Given this list of marker genes ASAH1, FAM83B, LINC02995, RNU6-924P, MALSU1, BRWD1, PRMT5-AS1, HSPA4, ZNF48, LINC00431, OGDH, ZNF345, RMND5B, SLC8B1, GDF15, RNU6-236P, TMEM91, RPL7AP7, ASGR2, IGHV5-51, PIAS1, RUNDC3A, ZNF790, STAT6, KRTAP10-8, LINC02757, NXPH4, IGHV5-78, ZFPM2, LMNA, ZNF503-AS1, MIR218-2, ITGA3 (NCBI Gene Id 4454), RBM23, PICART1, LZTR1, MED13, CCT6P1, ID4, PDE2A, BRD1, STK33, STARD3, COMMD10, CYP1B1-AS1, PDE2A-AS2, ASAH1-AS1, TRABD2A, KIF1B, EFCAB8, MFN1, MIR4286 (microRNA 4286), here is a description of the gene set: species: Homo sapiens from publication Yevshin I, Sharipov R, Kolmykov S, Kondrakhin Y, Kolpakov F (PMID 30445619) Human Gene Set: ZNF707_TARGET_GENES Genes containing one or more binding sites for (ZNF707) in their promoter regions (TSS -1000,+100 bp) as identified by GTRD version 20.06 ChIP-seq harmonization.